Given this list of marker genes Ttk, Lsm14b, Gdf9, Fosl1, Sycp2, Mettl3, Plk1, Ctnnb1, Agt, Washc1, Kat8, Stra8, Tut4, Sgo2a, Src, Rec114, Fbxo5, Brme1, Magoh, Sohlh1, Mcmdc2, Mmp2, Mei4, Ythdc2, Bcas2, Mlh3, Meiosin, Taf4b, Nrip1, Trim75, Hsf1, Spire1, Zar1l (NCBI Gene Id 547388), Mlh1, Nanos2, Rps6ka2, Nanos1, Sirt1, Ythdf2, Pgr, Ska3, Oas1d (NCBI Gene Id 97256), Amh, Septin1, Ezhip (EZH inhibitory protein), Ddb1, Kmt2d, Pla2g4a, Diaph2, Msh5, Zar1, Msh4, H3f3a, Terb2, Etv6, Cdc25b, Fmn2, Wdr77, Marf1, Rec8, Dcaf13, Lep, Pde3a, Gas2, Atm, Pde5a, Orc4, Tdrd1, Ppp2r1a, Edn2, Rps6, Ska1, Zfp830, Aurka, Tdrd5, Sycp3, Ythdc1, Pld6, Nos2, Mcm9, Cyp51, Tm9sf5, Zp3, Tut7, Spin1, Tdrd7, Oog1, Mmp19, Alms1, Zscan21, Paqr8, Kmt2b, Brca2 (breast cancer 2, early onset), Afp, Washc5, Nos3, Ncaph2, Prdm9, Tdrd6, Ska2, M1ap, Pabpc1l, Majin, Figla, Lgr5, Zmiz1, Hormad1, Piwil2, Oosp2, Nppc, Paqr5, Mdk, Sirt2, Trip13, Nobox, Dnmt3l, Ccnb1, Ndc80, Hexb, Immp2l, Pten, Aspm, Ddx20, Hrob, Sebox (NCBI Gene Id 18292), Ptk2b, Mcm8, Spire2, Meiob, Mos, Paqr7, Mei1, Adrm1, Rxfp2, Ihh, 4930447C04Rik, Bnc1, Ehmt2, Cenpe, Inhbb (NCBI Gene Id 16324), Ubb, Spdya, Kash5, Mastl, Top2a, Akt1, Plcb1, Tnfaip6, Ybx2, Insl3, Ccnb2, Hsf2bp, Shb, Bcl2, Ncaph, Meikin, Foxo3, Ednra, Sohlh2, Dnmt3a, Dnmt3b, Rbm46 (NCBI Gene Id 633285), Ptx3, Dmc1, Dmrt1, Npm2, Wee2, Ptn, Zglp1, Ereg, H3f3b, Cntrl, Zfx, Edn1, Igf1, Tdrkh, Ercc1, Hpgd, Meioc, Iho1, Spo11, Adamts1, Dazl, Sos1, Gpr149, Npr2, Wnt4, Bmpr1b, Pde4d, Nanos3, Grb14, Inhba, Hfm1, here is a description of the gene set: Generation of the female gamete; specialised haploid cells produced by meiosis and along with a male gamete takes part in sexual reproduction. species: Mus musculus Mouse Gene Set: GOBP_FEMALE_GAMETE_GENERATION